Given this list of marker genes SCAPER, NF1, PIK3CB, PAX9, GRIK5, GLE1, MSH3, IRF2, FUT6 (fucosyltransferase 6), IRS2, BNIP1, SULT2B1, SLC18A1, GJB5, TNFRSF25, POU6F1, TMPRSS6, JAG1, CYP2E1 (NCBI Gene Id 1571), CELA2B, SMYD5, SLC13A2, PRELID3A, SLC2A1, GPLD1, ZNF592, MFN1, MC5R, NFIC, GH1, PIGB, ATP6V0A2, PLEKHB1, JRK, DPT, AQP7, GNPAT, NRTN, HOXD4, RPS6KB2, HMOX2, PIGR, HOXA11, SLC22A6, ATP6V1B1, TFDP2, PCGF1, CYP2A6, KRT33A, HSD17B3, NXPE3, ABCC8, ABO, CAMK2G, WT1, FNTB, PVR, SLC4A3, ATP8B1, TMEM11, ENTREP1, ARL3, MYO9B, ERC1, CFH, C1orf216, KAT8, EPHB2, CCKAR, GSK3B, CYP11A1, OPLAH, CASP10, LY9, ESR1, SMPDL3B, SLC25A11, HTR7, KLHL18, TBX5, TMEM94, MSX1, ZBTB22, ABCB9, IKBKE, PRKACA, AQP5, PIGF, FIG4, POLR3D, CLOCK, CD6, PAXIP1, TBC1D22A, PGM3, NR2C1, COX6A2, SLC16A5, WBP4, SP140, IL13, SLC6A11, BRCA1, IFT27, CNKSR1, CDR2L, LTBP4, MAPT, STK17A, ZNF500, BCL2 (BCL2 apoptosis regulator), EXTL3, here is a description of the gene set: Human Gene Set: MORF_PRKACA species: Homo sapiens Neighborhood of PRKACA protein kinase, cAMP-dependent, catalytic, alpha in the MORF expression compendium Neighborhood of PRKACA